The following is a description of a gene set: Human Gene Set: GOBP_NEGATIVE_REGULATION_OF_EXOCYTOSIS Any process that stops, prevents, or reduces the frequency, rate or extent of exocytosis. species: Homo sapiens, and this is the list of marker genes: STXBP6, FCGR2B, CCR2, RABGEF1, IL13RA2, RAB7A, HLA-F, RAP1B, ADRA2A, SPI1, SMCR8, NOTCH1, REST, IL1RAPL1, CD84, ANXA1, CBARP, BCR, VPS4B, LGALS9, CDK5, SNCA, BRAF, RAB33B, GNAI2, WDR41, CD300A, SYT4, ATP9A, FOXF1, C9orf72, FMR1, RAP1A, RAP1BL, STXBP3, PRKN, NCKAP1L, CEACAM1